Given this list of marker genes TEX11, SMS, TP53 (tumor protein p53), DMPK, BMP6, AR, WFS1, HPRT1, HFE, NHP2, POLG, FGD1, PIGA, BMP2, ANOS1, FSHB, here is a description of the gene set: Testicular atrophy Human Gene Set: HP_TESTICULAR_ATROPHY Wasting (atrophy) of the testicle (the male gonad) manifested by a decrease in size and potentially by a loss of fertility. species: Homo sapiens